Given this list of marker genes PDXK, PRSS58, PCBP2, FAM110C, RAB10, SHISAL1, SLC30A4, SYCP1, CLDN3 (claudin 3), MFSD12, KHDRBS3, FOXF1, ELAVL1, PLXNB2, FRA10AC1, MMP11, DDR2, PRR12, CPM, DNM1, GSR, PLIN3, ARRB1, GAK, EXOC3L1, OR51B2, CDK2, SLC35E4, C8A, CCDC3, TXNL4A, MAPK6, CPA3, B4GALT2, CNIH1, LRRC26, RILP, ASB15, DDX50, BCR, PIH1D2, PLCG1, WDPCP, PDZK1IP1, TOMM40L, CACNA2D4, FAM170B, CARMIL1, RAI1, CISH, MAGED2, ACKR2, CHAF1B, SEMA6C, POM121L12, CC2D2A, ADA (adenosine deaminase), RNF122, PADI4, ARMCX6, TEKT1, S100B, MCTP1, DDX42, CKAP2L, CAPSL, ADI1, LONRF2, RPL28, SCRN3, PRPF40B, ZNF771, SLC5A2, THOC3, TNNI3, TCEAL1, MAOA, SETDB1, PINK1, MRPL2, AK4, AARS2, SRPX2, SLC2A10, COPS5, LRRN4CL, CCN4, PAK6, LSM3, ARL2, ZSWIM7, ABHD11, GAD1, STX3, PECR, GABRR1, GATAD1, MTX2, HSD17B12, P2RX1, CIMIP5, SMC1B, BRCA2, AUNIP, LRRTM3 (leucine rich repeat transmembrane neuronal 3), SIRPA, HDGF, CNKSR2, DNAJC21, DCLK2, LRRC8D, CHGA (NCBI Gene Id 1113), PCDH7, MYO1D, CHRNA4, SLC7A8 (NCBI Gene Id 23428), HOXA7, CAPN5, AAGAB, ALDH7A1, ISLR, CD79B, FADS6, HEBP1, GNGT1, ADSL, DAB2, TTYH3 (NCBI Gene Id 80727), MINDY4, RPL9 (NCBI Gene Id 6133), GSTM2, IQSEC2, RYK, TET1, PKM, IFT81 (NCBI Gene Id 83713), F8A1, FAH (NCBI Gene Id 2184), RBM28, GADD45A, CLSTN2, PPP4R4, BAG2, PDP2, SLC35C2, PDE8B, INSRR, SRRT, STAT5A, XKR8, NFAM1, ESAM, FAM110A, DHCR24, ABHD15, CIART, RHBDL3, CSTPP1, SSC5D, RENBP, RACK1 (receptor for activated C kinase 1), E2F6, VAX1, CIMAP1B, VPS18, GALK1, HACD1, KRT8, CDK4, DNTT, TBC1D9, IRF6, SPATA17, ABLIM3, GNA15, MAK, DTNBP1, STEAP2, KRT26, ARL4A, MZB1, PCSK4, OR51E1, JSRP1, PCLO, SLC45A4, LHFPL2, CACNB2, NHSL3, ASAH2, FBXO16, DGKG, TMEM200A, PPA2, SYT2, STARD10, APLN, PPP1R17, TEX30, SLC9B2, here is a description of the gene set: species: Homo sapiens from publication Kim TD, Terwey TH, Zakrzewski JL, Suh D, Kochman AA, Chen ME, King CG, Borsotti C, Grubin J, Smith OM, Heller G, Liu C, Murphy GF, Alpdogan O, van den Brink MR (PMID 18178870) Human Gene Set: GSE5503_LIVER_DC_VS_SPLEEN_DC_ACTIVATED_ALLOGENIC_TCELL_UP Transcriptional response of murine allogeneic T cells (B10.BR) after stimulation with different organ-derived (spleen, liver, peripheral and mesenteric lymph nodes) dendritic cells (C57BL/6) in vitro Genes up-regulated in allogeneic T cells after stimulation with dendritic cells from: liver versus spleen.